The following is a description of a gene set: electronically inferred by orthology from the curated human pathway This event has been computationally inferred from an event that has been demonstrated in another species.<p>The inference is based on the homology mapping from PANTHER. Briefly, reactions for which all involved PhysicalEntities (in input, output and catalyst) have a mapped orthologue/paralogue (for complexes at least 75% of components must have a mapping) are inferred to the other species. Reactome Pathway: TCR signaling part of: Adaptive Immune System studied in species Mus musculus, and this is the list of marker genes: Pik3cb, Psmc6, Psmb7, Lcp2, Pdpk1, Ube2n, Psmd1, Psma5, Psmb4, Rps27a, Cd3d, Psma6, Rela, Lat (NCBI Gene Id 16797), Ptprc, Ptpn22, Ikbkb, Psmc2 (proteasome (prosome, macropain) 26S subunit, ATPase 2), Psmc4, Pak3, Ube2d1, Plcg2, Malt1, Grap2, Ube2v1, Itk, Psmd7, Cul1, Trat1, Psmc3, Psmc1, Csk, Lck, Nfkbia, Pik3r2, Psma2, Psmd12, Tab2, Cd3e, Psma4, Pag1, Psma7, Psma3 (proteasome subunit alpha 3), Psmb6, Psmd13, Cdc34, Psma1, Psmb5, Nfkb1, Psmd6, Cd3g, Ubb, Psmc5